The following is a description of a gene set: In the initial response to injury, platelets adhere to damaged blood vessels, responding to the exposure of collagen from the vascular epithelium. Once adhered they degranulate, releasing stored secondary agents such as ADP and ATP, and synthesized thromboxane A2. These amplify the response, activating and recruiting further platelets to the area and promoting platelet aggregation. Adenosine nucleotides secreted following platelet activation signal through P2 purinergic receptors on the platelet membrane. ADP activates P2Y1 and P2Y12 while ATP activates the ionotropic P2X1 receptor. Activation of these receptors initiates a complex signaling cascade that ultimately results in platelet activation and thrombus formation. ADP stimulation of P2Y1 and P2Y12 involves signaling via both the alpha and gamma:beta components of the heterotrimeric G-protein. studied in species Homo sapiens Reactome Pathway: Signal amplification part of: Platelet activation, signaling and aggregation, and this is the list of marker genes: GNG4, AAMP, GNG2, GNAQ, GNB2, GNB3, GNG10, PLA2G4A, TBXA2R, GNA13, SRC, GNA14, GNB4, GNA15, GNG13, GNG7, GNGT1, GNG11, GNG3, GNG12, GNAI3, GNAI2, P2RY12, GNGT2, GNB5, GNB1, P2RY1, GNAT3 (NCBI Gene Id 399515), GNA11, GNG5, MAPK14, GNAI1, GNG8